The following is a description of a gene set: species: Homo sapiens Any process that increases the rate, frequency or extent of the Fc receptor mediated stimulatory signaling pathway. Human Gene Set: GOBP_POSITIVE_REGULATION_OF_FC_RECEPTOR_MEDIATED_STIMULATORY_SIGNALING_PATHWAY, and this is the list of marker genes: CD226, LYN, RAP1A (NCBI Gene Id 5906), APPL2, PTPRJ, PTPRC (NCBI Gene Id 5788)